Given this list of marker genes NBAS, SYT17, TNFAIP2, DAPK1, SNAP29, SLC6A4, VTI1A, GOSR2, SNAP47, TXLNB, STX1B, STX3, CPLX4, STX16, STX19, VAMP8, CPLX3, GABARAPL2, STX12, NSF, TMED9, SYT1, BAIAP3, EXOC3L4, GRIK2, VPS52, RAB11A, SYT15, STX2, SYT10, PICALM, VPS18 (VPS18 core subunit of CORVET and HOPS complexes), VTI1B, ABCA1, STX8, VAMP3, SYT4, SYT6, KCNB1, SNAPIN, VAMP2, NAPG, ANKRD27, TPCN1, PRRT2, STXBP5, HECTD3, STX11, STXBP1, STX5, SYT2, SEC24C, BLOC1S6, SYT11, STX10, VPS54, TSNARE1, STX4, SYT3, SYT7, EXOC3, STX1A, NAPB, TXLNA, PTPN2, NAPA, SYT9, SYT5, SYT12, STX7, SEC24D, SYT13, STXBP4, UVRAG, TXLNGY, SNCA, DOC2B, SNAP91, CACNA1A, SEC24B, STX17, SEC24A, TMED10, VAMP1, ABL1 (NCBI Gene Id 25), UNC13B, LRRK2, EXOC3L1, CPLX1, CAPN10, GOLGA2 (NCBI Gene Id 2801), VPS50, STX6, SNAP25, VAMP7, VPS11, STXBP3, SCFD1, TXLNG, SNAP23, SYT8, STXBP5L, STXBP2, UNC13C, SNPH, UNC13A, CPLX2, here is a description of the gene set: Human Gene Set: GOMF_SNARE_BINDING Binding to a SNARE (soluble N-ethylmaleimide-sensitive factor attached protein receptor) protein. studied in species Homo sapiens